The following is a description of a gene set: Human Gene Set: GOBP_NEURON_INTRINSIC_APOPTOTIC_SIGNALING_PATHWAY_IN_RESPONSE_TO_OXIDATIVE_STRESS species: Homo sapiens The series of molecular signals in which an intracellular signal is conveyed to trigger the apoptotic death of a neuron. The pathway is induced in response to oxidative stress, a state often resulting from exposure to high levels of reactive oxygen species, and ends when the execution phase of apoptosis is triggered., and this is the list of marker genes: HIF1A, PARP1, AKT1, IL10, MIR195, CTNNB1, FBXW7, PARK7, PRKN, DAXX, WNT1, FGF2, FZD1, TREM2, MCL1, PRODH, NONO, ADCY10 (NCBI Gene Id 82259), MAP3K5, PINK1, ATF4, FBXO7, MMP2, PYCR1